Given this list of marker genes FDX1, FDXR, FDX2 (NCBI Gene Id 2143), here is a description of the gene set: part of: Mitochondrial iron-sulfur cluster biogenesis Reactome Pathway: Electron transport from NADPH to Ferredoxin species: Homo sapiens NADPH, ferredoxin reductase (FDXR, Adrenodoxin reductase), and ferredoxins (FDX1, FDX1L) comprise a short electron transport chain that provides electrons for biosynthesis of iron-sulfur clusters and steroid hormones.